Given this list of marker genes Iscu, Hsd3b6, Hamp2, Nos1, Hsd3b2, Hsd3b3, Hamp, Atp7a, here is a description of the gene set: studied in species Mus musculus Any process that stops, prevents, or reduces the frequency, rate or extent of the directed movement of iron ions into, out of or within a cell, or between cells, by means of some agent such as a transporter or pore. Mouse Gene Set: GOBP_NEGATIVE_REGULATION_OF_IRON_ION_TRANSPORT